The following is a description of a gene set: part of: SLC transporter disorders studied in species Homo sapiens The human gene SLC35A3 encodes a UDP-GlcNAc transporter. It is ubiquitously expressed and resides on the Golgi membrane where it transports UDP- N-acetylglucosamine (UDP-GlcNAc) into the Golgi lumen in exchange for UMP. UDP-GlcNAc is a substrate required by Golgi-resident glycosyltransferases that generate branching of N-glycosylated proteins. Defects in SLC35A3 can cause arthrogryposis, mental retardation, and seizures (AMRS; MIM:615553). Patient cells show a large reduction of tetraantennary N-glycans with an accumulation of abnormal lower-branched glycoproteins, although the serum N-glycome was normal. Reactome Pathway: Defective SLC35A3 causes arthrogryposis, mental retardation, and seizures (AMRS), and this is the list of marker genes: SLC35A3